The following is a description of a gene set: Any process that stops, prevents, or reduces the frequency, rate, or extent of CD4-positive, alpha-beta T cell differentiation. studied in species Homo sapiens Human Gene Set: GOBP_NEGATIVE_REGULATION_OF_CD4_POSITIVE_ALPHA_BETA_T_CELL_DIFFERENTIATION, and this is the list of marker genes: ANXA1, TNFSF4 (TNF superfamily member 4), RUNX1, RUNX3, HMGB1, CD69, RC3H2, IL2, TNFSF18, LOXL3, TBX21, ZC3H12A (zinc finger CCCH-type containing 12A), STAT5A (NCBI Gene Id 6776), ZBTB7B, SOCS5, LGALS1, CBFB, SMAD7, HLX, JAK3, ASCL2, RC3H1, FOXP3, IL4R, BCL6